The following is a description of a gene set: Genes down-regulated in T reg following anti-CD3 in vivo treatment versus control. Human Gene Set: GSE22527_ANTI_CD3_INVIVO_VS_UNTREATED_MOUSE_TREG_DN Treatment with anti-CD3 is a promising therapeutic approach for autoimmune diabetes, but its mechanism of action remains unclear. Foxp3+ regulatory T (Treg) cells may be involved, but the evidence has been conflicting, and there is great uncertainty as to possible mechanistic connections. We investigated this issue in mice derived from the NOD model, which were engineered mice in which Treg populations were perturbed, or could be manipulated by acute ablation or transfer. The data highlighted the involvement of Foxp3+ cells in anti-CD3 action. Rather than a generic influence on all Treg cells, the therapeutic effect seemed to involve an striking expansion of previously constrained Treg cell populations; this expansion occurred not through conversion from Foxp3- Tconv cells but from a dramatic proliferative expansion. We found that Treg cells are normally constrained by TCR-specific niches in secondary lymphoid organs, and that intraclonal competition restrains their possibility for conversion and expansion in the spleen and lymph nodes, much as niche competition limits their selection in the thymus. The strong perturbations induced by anti-CD3 overcame these niche limitations, in a process dependent on receptors for trophic cytokines, interleukin-2 receptor (IL-2R) and IL-7R. from publication Nishio J, Feuerer M, Wong J, Mathis D, Benoist C (PMID 20679403) species: Homo sapiens, and this is the list of marker genes: IARS2, TELO2, MTCL1, RPS6KA1, HBP1, ZBTB18, FNTA, TRIM5, RPS29, BAG2, RSAD1, YLPM1, PDCD6, CDC23 (NCBI Gene Id 8697), GMNN, GLE1, PCMTD2, RNF8, PPP5C, ST8SIA4, BARD1, FBXO46, EIF2B1, SCCPDH, SORT1, AICDA, SNRNP25, DCUN1D4, EXT2, C21orf91, HAUS7, MTHFD1, NUP37, SLC39A14, HEY1, ANAPC5, RPL12, PEX6, RETREG3, KRCC1, NPTN, SLC25A5, ZNF10, SEPTIN8, EXOC1, SET, TAF5, HSPE1, SGPL1, TPP1, DSN1, COX7A2 (NCBI Gene Id 1347), RXYLT1, ELMO1, REXO4, DOP1B, GOLGA1, KDM6A, WDR25, MCCC2, GOLPH3L, AKR1A1, BCOR, ZNF225, NARS1, TJAP1, SMIM8, PRIM1, MRPL15, CCNB2, OTUB1, TUBG1, INHBE, TUBD1, BUB1B, ATAD2B, GAPVD1, TRANK1, VAMP8, COA3, P4HA2, SSX2IP, RERE, ERAP1, NFE2, KDM1A, FBP1, MCM9, IKZF1, ORC1, TP53, LTBR, PEX1, RBBP5, SETD4, PRICKLE3, CAND1, GLOD4, POLRMT, ELP6, RAB5IF, NAT10, VAV3, CEP192, ZNF669, C1orf216, STAG3, PIAS3, KAT7, SLC35A1, XPO7, MAP3K11, ZDHHC7, FUT8, PTPN18, PLEKHA1, PMS2P1, GFOD1, TJP2, MACROD1, SNRPD3, REV3L, SYNM, ZSCAN31, GLT8D1, PIP4K2B, NOP56, UBR7, BIRC5, TOR3A, FSCN2, POLD3 (DNA polymerase delta 3, accessory subunit), RARS1, GPN2, UBXN8, BMAL1, FASTK, MRTFB, HBS1L, SUPT20H, R3HCC1, GATD3, CD164, PLSCR1, LSM4, CYB561D2, FAM216A, PSD4 (NCBI Gene Id 23550), NOLC1, RAB20, PURA, FLI1, ELAVL1, IPO9, ICA1, ATP5F1B, MIEF1, TNFAIP8, ATP5MG, FES, SMC3, UQCRFS1, CIRBP, TYMS, RRAGC, OIP5, DIXDC1, ZNF135, TCFL5, BBS4, RFTN1, ABHD4, MGST3, ZNF573, UBE3B, PTGES3, DCAF17, NGDN, ARFIP1, RANBP1, ZBTB25, REEP5, MRPL20 (NCBI Gene Id 64994), HOXA5, RAD9A, NLRX1 (NCBI Gene Id 79671), GFUS, KRIT1, CTCF, OSGEP, KIAA0232, ZZZ3, EDF1, ZNF184, HSPD1 (NCBI Gene Id 56733), MGA, RANGRF, SESN1, KDM3B, C11orf71